The following is a description of a gene set: Onset of signs or symptoms of disease between 28 days to one year of life. studied in species Homo sapiens Infantile onset Human Gene Set: HP_INFANTILE_ONSET, and this is the list of marker genes: ZMYND10, CRELD1 (NCBI Gene Id 78987), MBD5, EPCAM, CYP24A1, TGM3, DBR1, GNPNAT1, CD59, ARFGEF2, RINT1, PURA, YWHAG, ENPP1 (NCBI Gene Id 5167), CARD14, WLS, RPS6KA3, IL2RB, G6PC1, CCDC39, TOGARAM1, ANKH, TRAPPC2L (NCBI Gene Id 51693), SLC46A1, HERC2, DPM1, ATP1A3, HNRNPH2, MANBA, SLC18A2, TIMM50, GUCY2D, B9D1, TCEAL1, CD79B, RIPK1, NDUFB9, RFX7, SLC6A8, SLC38A8, FTH1, SNORD118, IRAK4, CPLANE1, GNB2, ALDH18A1, CLPX, NBAS, PSAP, ATG7, LMBRD1, GNS, CAMSAP1, TSEN15, SERPINF1, RPS29, CFAP410, FBP2, NDUFV1, AMPD2, POLG2, RDX, SLC31A1, TNFRSF11B, ERF, SDHD, CUX2, NDUFAF8, CARS2, ADAT3, DLD, BLNK, ZNF407, GLYCTK, CACNA1I, PRKG2, KCNT1 (NCBI Gene Id 57582), AGR2, MRPS7, STING1, FUCA1 (NCBI Gene Id 2517), ELF4, SLC9A7, RAG2, LAT, ABHD16A, TCF3, TET2, MED17, EHHADH, GABRA1, RPS26, KRT83 (NCBI Gene Id 652010), KMT5B, NEFL, GJB2 (NCBI Gene Id 2706), DCC, HNRNPU, MYMX, FBXL4, OCLN, ANAPC7, ASH1L, EXOSC8, ADGRV1 (NCBI Gene Id 84059), MGAT2 (NCBI Gene Id 4247), ALG2, IDS, PLG, NAPB, NUP62, LIPT1, ADA, RPSA, ATP2B3, PERP, VPS45, BRF1, ZIC1, KCNC2 (NCBI Gene Id 3747), SLC39A7, FCHO1, HNMT (histamine N-methyltransferase), HEXA, ISCA1, AUH, COQ8A, ALG14, DPF2, GTPBP2, ADCY3, LYSET, RRAGC, CD3G, HMGCS2, DIAPH1, NFIA, NPHP3, SLC6A6, NAXE, MTX2, TMTC3, TUBB6, GABBR1, COX6A2, POMT2, GPR101, MMUT, STAT3, POMK, MDH2, CFTR, SLC41A1 (NCBI Gene Id 254428), ROR1, P4HTM, EIF2B5, SCO2, VPS53, AKT2, TBX19 (T-box transcription factor 19), CTDP1, RAB27A, ABCD3, ZMYM2, DNA2, TPK1, COG3, COPB1 (COPI coat complex subunit beta 1), FGFR1, PCDH12, PSMB9, SDHAF1 (succinate dehydrogenase complex assembly factor 1), PRDM13, LAGE3, GOLGA2, ATP6AP2, SUPT16H (NCBI Gene Id 6831), TBC1D7, NKX6-2, DNM2, SNUPN, CYP2R1, SLC26A3, TUFM, CACNA1C, IRF1, FLT4, SEC23B, ACADVL, ISCA2, TINF2 (TERF1 interacting nuclear factor 2), CIC, FLAD1, CAMTA1, RBCK1, CCDC115, FOXC1, HEXB, SLC33A1, SEPSECS, EIF2AK1, PHIP, DOLK, DCLRE1B, EBF3, UBE3C, IL36RN, GNB5, ATAD3A, CBLB, SON, RPGRIP1, CRX (NCBI Gene Id 1406), SETD1A, SPARC, NFKBIA, KIF12, TMEM199, UQCRQ, POMT1, EIF2AK3, SMARCA4, CHST3, ANOS1, LRIG2 (NCBI Gene Id 9860), TMEM106B, HGD, SLC18A3, ADNP, PCNA, GFI1B, ADCY5, POLRMT, ADD3 (adducin 3), C1GALT1C1, EDEM3, MRPL3, MTHFS, CYP2U1, TBCD, GRM1, MLC1, MACF1, DST, FKTN, SLC25A1, CNNM2, ST3GAL3, IDH3A, MAST1, COL6A1, VLDLR, PTEN, HAX1, TNFAIP3, PEX14, CDH3 (cadherin 3), TAFAZZIN, PTPRC, CTC1, CTNNB1, IRF8, PRX, DCDC2, TNFSF11, MMP13, NCDN, GABRB3, HYDIN, SLC25A15, KRT5, WDR45B, ATP7A, AQP4, NKX2-1, GATM, AHCY, GRIN1, THUMPD1, HID1, TECR, ANTXR1, ITPR1, GLUL, NDUFB8, DUT, ARV1, ABCC6, LGI3, NEB (nebulin), GRIK2, TRPM6, PI4K2A, TWNK, PTH (NCBI Gene Id 5741), ZAP70, PLCG2, NCF2, MT-TN, HIVEP2, FERMT3, MCCC1, NLRP1, AIRE, RNH1, ZNF668, NTRK1, TPM2, TRMT1 (NCBI Gene Id 55621), CYB561, COLQ, PLCB1, MAFB (MAF bZIP transcription factor B), CD19, JAGN1, CLP1, JPH1, THOC6, TJP2, DGKE, KARS1, TK2, TUFT1, ZNF526, DGUOK, SRP68, MTRR, GJB3, SIL1, ALG12, PEX2, SLF2, COQ4, PHOX2B, ATG5, BCKDK, IGLL1, NDUFS4, PPP2CA, SLC6A17, VPS33B, PDE10A, MMACHC (metabolism of cobalamin associated C), CD3D, HCN2, SCN11A, GPAA1, RNF31, PNP, SGCD, TPP2, OPA1, AEBP1, TANGO2, FOCAD, LCK, CRB2, RPS10, KMT2E, PLAA, MRPS2, CLPB, LEPR, BCL11B, NTN1, GEMIN5, HNRNPA2B1, C12orf57, RARS1, VPS33A, PNKD, TUBB4A, GARS1, GLUD1, RIN2, TCN2, ST3GAL5, POLE, NR1H4, HTT, TRAPPC9, HADHA, MECP2, BCAP31, TAF13, MYMK, TRDN, DDX3X, GPHN, WDR62, SRD5A3, ZMYM3, ALG13 (NCBI Gene Id 79868), ATP6V1A, COL11A1, WAC, CAD (carbamoyl-phosphate synthetase 2, aspartate transcarbamylase, and dihydroorotase), TRAPPC6B (trafficking protein particle complex subunit 6B), ERBB2, RNU12 (RNA, U12 small nuclear), NEUROD2, ELP2, RAD51, GABRG2, GPR143, RAP1GDS1, ATP6V0A1, ALS2, UPB1, NAA60, IFNG, STAT6, SLC19A1, DYRK1A, COG2, PGAP2, SCN8A, MTO1, MATN3, RSRC1, TRAPPC12, TBK1, CALM1, PDE2A, SMC3, HNF1A, TCF20, LZTR1, SELENBP1, RUSC2, MMAA, TRIM2, ASS1 (NCBI Gene Id 445), AIFM1, SKIC2, CTNNA2, WDR81, ACTA1, HCN1, EXOSC2, MCTS1, COL4A1, ERLIN2, HPD, IL2RG (interleukin 2 receptor subunit gamma), MLIP, DAW1, SI, TBL1X, CEBPE, HIBCH (NCBI Gene Id 26275), WDR4, GRIN2B, SLC34A3, JAK3, ZSWIM6, POLG, SLC12A6, RORC, KCNJ10, POLR1C, POGZ, S1PR2, GM2A, REPS1, SATB2, GMPPA, RPL3L, DCLRE1C (NCBI Gene Id 64421), SLC25A42, ACTB, SARS2, ATP6AP1, YME1L1, RAB11B, SH3KBP1, NMNAT1 (NCBI Gene Id 64802, nicotinamide nucleotide adenylyltransferase 1), PMPCB, RFXANK, COL27A1, COX5A, TUBGCP2, RPGRIP1L, KCNH1 (NCBI Gene Id 8656), CHKB, ACADSB, GGT1, SCN4A, CTBP1, SUCLG1, IFITM5, TOMM7, POC1B, CUX1, YIPF5 (NCBI Gene Id 81555), DOCK3, FRMD7 (NCBI Gene Id 90167), COQ2, AGO2, GJA1, SPRED2, KAT6B, AFG2A, WWOX, RERE, MEFV, SET, DPYD, PUS1 (pseudouridine synthase 1), SMARCC2, AKT1, AASS, ZBTB18, KIDINS220, SAMD9, AIMP1, AIMP2, SLC2A1, UNC13D, SERPINB7, EXOSC5, SEC61A1, ATP9A, ZMIZ1, ADGRG1, POMC, KDELR2, FZD4, MID2, ABCB7, ALG9, PSMB8, VARS1, USH1C, NDP, MRPS34, JAK2, CREBBP, SLC1A4, PEX16, KCNQ2, ADK, PLP1, FCGR3A, RELB, ADAM22, TRIT1, MPZ, IFT56, COL1A1 (collagen type I alpha 1 chain), SCN2A, TTI2, CASK, RUBCN, PCYT1A, PIGM, NDUFA1, HDAC4, COG4, SPATA7, ZFYVE19, NDUFAF3, ERCC1, SCN9A, TRIOBP, SAR1B, TRIP13, DNAAF4, BRD4, SGPL1, RYR1, VPS41, CRB1, NLRP12, GRIN2D, CCDC65, CRLS1, IRF2BPL, ATP8B1, ZNF142, ATP6V0C, REST, PUM1, PCDH19, NDUFC2, KITLG, EXOC7, NSUN6, MTMR14, TAF2, DAG1, GPT2, TTI1, PDGFRB, C4B, CBL, GNE, GON7, MTOR, NEDD4L, CSF3R, MMADHC, LMNA, DKC1, RPL21, PMM2, IFIH1, STXBP2, SVIL, RNPC3, GNPTAB, STAG1, SACS, MTR, SNAP29, CDKL5, BRWD3, SEMA7A, LYRM7, LARGE1, H4C9, COL6A2, TP63, KDM6B, MMAB, NAA20, SCN1B, PLXND1, GALC, TSC2, KDM5B, SHARPIN, CD79A, P4HB (prolyl 4-hydroxylase subunit beta), ITPA, SZT2, PIK3CD, DPAGT1, CD3E, SETBP1, NCKAP1L, TBX21, NDUFS1, SLC1A2, TARS2, CHKA, SDHB, IFT140, SCN3A, OPHN1, PUS3, HECTD4, COX11, SLC16A1, CAVIN1, UBA5, ELOVL1, DIP2B, SCAF4, SLC25A38, AFG3L2, ERCC8, STAT2, MCM5, NDUFA2, NEK10, BTD, KRT14, IL37, STXBP1, SELENON, D2HGDH, AGO1, HCFC1 (host cell factor C1), FGF13, OAS1, AMMECR1, SURF1, OSTM1, UFC1, UVSSA, POLR3B, PMPCA, PIGT, PCDHGC4, NSUN3, OTUD7A, MTFMT, ARHGEF9, AP1S2, HNRNPC, PSMG2, SYK, WARS2, TLR8, YARS1, GJC2, FYCO1, KDM6A (NCBI Gene Id 7403), DPP9, EPRS1, SP7, IARS2, GRIA3, H4C5, TIAM1, CARD11, ECM1, MBTPS1, WAS, HIKESHI, FAR1, POMGNT2, SMG9, FMN2, CUL3 (cullin 3), QDPR, GRIA1, PDZD8, MYH3, GAD1, RORB, L2HGDH, LRP5, SCYL1, CYC1, ABCB4 (NCBI Gene Id 5244), PTCHD1, MCOLN1, SAMHD1, ZNFX1, FGB, PIGW, GOSR2, CLCN3, NGF, CHD2, UQCRB, TSHB, WARS1, EDA, GCSH, MED12 (mediator complex subunit 12), FKBP10, MFN2 (mitofusin 2), CACNA1H, SYNE4, B3GALT6, SLC2A2, ANKS6, NT5C2, AP5Z1, ELAC2, TGFB1, MCCC2, ARPC5, AGK, MCEE, SERPINB8, SLC7A7, U2AF2, LTBP1, TOM1, GUSB, UNC45B, ATR, SOX18, RLBP1, AARS2, SPTBN2, ACADS, ITGA3, GFAP, PRKDC, AFG2B, BICD2, POU1F1, NDUFAF6, CYBB, TELO2, HCRT, PPCS, EARS2 (glutamyl-tRNA synthetase 2, mitochondrial), SOD1, SPTSSA, TBR1, WDR26, ABCC9, VPS37A (NCBI Gene Id 23687), CACNA2D1, IKBKG, MSX2, CWF19L1, MRPL44, ADAMTS2, CHD8, ADAR, CAMLG, UFSP2, NIPBL, TNIK, GLB1, COQ6, EPO, KLK4, KDR, MAPK8IP3, SLC5A6, MIPEP, B4GALNT1, IKBKB, VAMP1, FNIP1, PKHD1, TIMMDC1, IL6R, GUCY1A1, CEP104, ATP6V1B2, PIGC, PLS1, NDUFV2, POLD3, EXOC2, KCNJ11 (potassium inwardly rectifying channel subfamily J member 11), RPE65, PDZD7, FYB1, FRMD5, FGG, HADHB, COLGALT1, ATP5F1A, PPP1R13L, DZIP1L, MVK, TP53RK, NSUN2, FIG4 (NCBI Gene Id 9896), SH2B3, SLC11A2, COPB2 (COPI coat complex subunit beta 2), PET100, AARS1, PAK1, C3, VAMP2, RNU4ATAC, GLS, IMPDH1, PIGL, FCGR2A, CACNA1B, NDUFA13, ALPK3, CACNA1A, NDUFA8, MYH7, RMRP, PRRT2 (proline rich transmembrane protein 2), PGM2L1, PIK3R1, LCA5, RETREG1, CPT2, KCNT2, CNPY3, SLITRK2, BLM, KLHL7, NARS2, CNOT3, CHRNA1, PEX1, CHRNE (cholinergic receptor nicotinic epsilon subunit), CACNA1G, CNTNAP2, TBL1XR1 (TBL1X/Y related 1), MYO5A, TCTN2, TSC1, MEGF10, STEAP3, YARS2, NDST1 (NCBI Gene Id 3340), CAMK2G, CAMK2B, NDUFA10, MTPAP, SLC35B2, USB1, TMEM63C, SH3TC2, NEMF, NSD2, ARPC1B, DHX9, CLDN11, PPIB, SIN3A, BCKDHB, KIF5A, PIDD1, AUTS2, SRRM2, FOXG1, SLC35C1, DHX30, TMEM67, ERMARD, COX10, NTRK2, PEX12, TRAC, ALDH5A1, HSD17B10 (hydroxysteroid 17-beta dehydrogenase 10), SLURP1, IL17RC (interleukin 17 receptor C), ACO2, DOCK8, IL6ST, KCNQ5, NEK8, GPRC5B, CAPRIN1, RAG1, ASPA, TRAF7, TBCK, ACOX1, PCLO, NOS1AP, KCNB1, TMX2, FANCB, MPDU1 (NCBI Gene Id 9526), ZNF462, SLC2A10, ZMPSTE24, PI4KA, RSPRY1, PDHA1 (NCBI Gene Id 5160), JAG1, SASH1, PLAAT3, ADA2, LMBRD2, GAN, DYNC1H1, MMP2, IGHM, NAXD, UBTF, GBA1, STX11, ALDOA, NOTCH2NLC, PHKA2, ZMYND11, CLCN7, TBC1D8B, ATP6V0A4, ETHE1, SLC37A4, PPA2 (NCBI Gene Id 92033, inorganic pyrophosphatase 2), FANCL, LRRK1, SLC35A1, SHQ1, MAP3K14, AMFR, INTS11, ASNS, PTS, PIGA, MYO5B, ACTL6B, RPS19 (NCBI Gene Id 8378), SYNGAP1 (NCBI Gene Id 8831), CRYAB, CHD5, GALNS, AGTPBP1, HMGCR, COX15, KLC2, EIF4A2, LMAN2L, MAP2K2, APOB, MED23, DOCK11, SOBP, BCORL1, PHKG2, MPI, ADSL, CAV1, PINK1, GEMIN4, FHL1 (NCBI Gene Id 2273), KCTD7, ATP13A3, KCNMA1, NSRP1, ALG8, BAAT, TXN2, CHD1, CLCN4, MRPS25, NFE2L2, SNX10, RFT1, UBE2A, MTSS2, CD40LG, NARS1, TUBB2A, HSPG2, SARS1, ALG11, TYMS, ATP1A2, SLC25A26, NGLY1, ISG15, SLC39A4, STS, MARS1, MBOAT7, MRPL39, TBXA2R, SNAPC4, SMN1 (NCBI Gene Id 91918), TNNT2, NBEA, NAGA, DDC, MALT1, SLC25A12, GDAP1, LMNB1, RPL35A (NCBI Gene Id 6165), PNPT1, ZNF408, GP6, PIGP, OTULIN, EXT2, SLC39A14, GH1, GFPT1, KMT2D, NACC1, TNPO2, EGR2, TRIO, G6PD, SYT1, GGCX, GCH1, ARID2, LETM1, BCAS3, NF1, GUCY2C, DSPP, EXTL3, MED25, SLC1A3, CLXN, SMPD1, FBXL3, VDR, TRPM4, CLDN19, WBP4, SNX14, FRRS1L, TULP3, CYP1B1, TAF8, SLC51A, FOSL2, OFD1, ERCC5, GTPBP3, RECQL, INPP5K, DOCK7, FARSB, OGDH, RLIM, CXCR4, GRHL2, GATAD2B, H3-3B (H3.3 histone B), DTYMK, MTHFD1, PHEX, MAST3, NR4A2, LRPPRC, MFF, RFXAP, LINS1, GNB1, ILDR1, COQ8B, SRCAP, MAGI2, THPO, CALR, CHRND, KCNH5, PYROXD1, TMEM163, HCN4, KDM4B, SLC6A3, DDOST, GNAS, YRDC, AVPR2, PGAP3, CAST, ACER3, IL10RB, CHMP1A, EFL1, NDUFA6, PITRM1, PPP3CA, APC2, SLITRK6, GPD1, MAGEL2, MPV17, AP3B2, SRPK3, RRAGD, DLG4, POLD1, ROBO3, SLC52A3, TRNT1, PSPH, TRMU, LAMB2, BOLA3, CD320, TLK2, AMBN, POLR1A, TSPYL1 (NCBI Gene Id 7259), FOXP3, SLC38A3, CTNS, PC, INPP5E, SETD5, TTN, CACNA1S, YIF1B, DNAH5, PIGK, PCK1, KCNN4, EIF2AK2, FLNA, IL21, CHD3, CERS1, TBC1D23, DHPS, WASHC4, GRID2, SOST, ACOX2, MEF2C, NLRP3, AXIN1, EP300, COG8, TEFM, DEPDC5, FGF12, TGFBR2, PSMB10, TPO (thyroid peroxidase), PRKACG (NCBI Gene Id 5568), NR0B1, PRDX1, DNM1, DRC1, EFEMP1, FLII (FLII actin remodeling protein, NCBI Gene Id 2314), TP53 (NCBI Gene Id 7157), PUS7, PIGS, QARS1, SPTAN1, NLRC4, LTV1, SLC25A36, CORO1A, CLDN16, RANBP2, CPSF3, CLMP, CD55, LIG1, C2orf69, RNASET2, DSC3, IREB2, PANK2, NAA80, SCN1A, KCNN2 (NCBI Gene Id 3781), PIGG, RFX5, SOX6, TNFRSF11A, CLTC, ANTXR2, PTRH2, SUCLA2, GRIA4, OTC, BCL10, FTSJ1, CRBN, DDB1, PLEKHG2, DEAF1, DLAT, NFU1, GATA1, MMP14, SYNJ1, KRT86, ANK1, STX1B, KIF1A, KRT10, PRKAR1B, CD247, AGXT, TRPA1, MUSK, IL7R, PHKB, CACNA2D2, VHL, NDUFAF1, NDUFA12, FGA, TULP1, METTL23 (methyltransferase 23, arginine), MMP9, FZR1, BCS1L, POLH, DEF6, TGFBI, SLC30A9, EIF3F, MYT1L, PLPBP, PLCE1, AMTN, DNAAF5, ABCB11, ATP1A1, CELF2, BRAT1, ARFGEF1, TPR, VARS2, ITGA7, MYO7A, ATP5F1B, PARN, CNTN1, LONP1, TH, NEXMIF, VPS13D (NCBI Gene Id 55187), PSMC1, FRMPD4, COX4I2, CA12, TRPV3, POLR3K, TNNT1, LINGO1, PMP22, GNAO1 (G protein subunit alpha o1), CNNM4, TRIM37, GRHPR, STK4, ANGPT2, IFNAR1, DDHD1, PACS2, CYP27B1, HPS6, CPLX1, TMEM38B, GABBR2, PROC, JAG2, GABRB1, RNASEH2A, TWIST1, MED13L, GMPPB, GAMT, TBCE, KPNA3 (NCBI Gene Id 3839), DCX, COL7A1, GLRA1 (glycine receptor alpha 1), SLC5A7, KCNJ13, ALDH6A1, NCAPD3, KCNA2, TNR, TCIRG1, GCDH, NDUFS2, NADK2, WDR73, PRF1, HPRT1, LRP1, EPG5, RAC1, PTPRQ, MIA3, PRDM12, SPEG, IQSEC2, MPL, RHOBTB2, USP53, HPS5, AHDC1, SDHA (succinate dehydrogenase complex flavoprotein subunit A), HPDL, PGAP1, EEF1A2, LIPA, CAPNS1, ELANE, LYST, CARMIL2, FOXP1, CSNK2A1, CAMK2A (calcium/calmodulin dependent protein kinase II alpha), STT3A, HEPACAM, ARSB, DARS1, COL12A1, ATCAY, ARPC4, ERCC6, CHAMP1 (chromosome alignment maintaining phosphoprotein 1), DOCK2, ERCC2, TRPV4, B3GALNT2, DYNC1I2, DPH2, TREX1, ATP2B1 (NCBI Gene Id 490), TBC1D24, BTK, HUWE1, WNK1, POLR3A, CFI, EPHB4, SPR, SLC32A1, SV2A, GET4, PTF1A, IL12B, SLC12A5, CLCNKB, CADM3, MICOS13 (NCBI Gene Id 125988)